The following is a description of a gene set: Human Gene Set: GOMF_LIPOPROTEIN_PARTICLE_RECEPTOR_ACTIVITY Combining with a lipoprotein particle and delivering the lipoprotein particle into the cell via endocytosis. A lipoprotein particle, also known as a lipoprotein, is a clathrate complex consisting of a lipid enwrapped in a protein host without covalent binding in such a way that the complex has a hydrophilic outer surface consisting of all the protein and the polar ends of any phospholipids. species: Homo sapiens, and this is the list of marker genes: LRP6, STAB1, LRP8, LRP1, LDLR, OLR1, LRP2, ILDR1, CXCL16, VLDLR, LRP1B, SORL1, APOBR, SCARB1, STAB2, CD36, LRP12, LRP10